Given this list of marker genes Tbx21, Il1r1, Arid5a, Xcl1, Il18, Il1b, Slamf1, Il18r1, here is a description of the gene set: species: Mus musculus Mouse Gene Set: GOBP_REGULATION_OF_T_HELPER_1_CELL_CYTOKINE_PRODUCTION Any process that modulates the frequency, rate or extent of T-helper 1 cell cytokine production.